The following is a description of a gene set: species: Mus musculus Mouse Gene Set: GOMF_PEPTIDYL_TRNA_HYDROLASE_ACTIVITY Catalysis of the reaction: an N-acyl-L-alpha-aminoacyl-tRNA + H2O = an N-acyl-L-amino acid + a tRNA + H+., and this is the list of marker genes: Ptrh2, Ptrh1, Ptrhd1, Mrpl58 (NCBI Gene Id 68572), Etf1